Given this list of marker genes USP8, ERBB2, HSP90AA1, EGFR, AKT2, ERBB3, CDC37, NRG2, NRG4, HBEGF, AKT3, EREG, PTPN12 (protein tyrosine phosphatase non-receptor type 12), CUL5, BTC, MATK, NRG1, NRG3, UBA52, ERBIN, AKT1 (NCBI Gene Id 207), RPS27A, UBC, STUB1, ERBB4, PTPN18, RNF41, EGF, UBB, here is a description of the gene set: part of: Signaling by ERBB2 Signaling by ERBB2 can be downregulated by ubiquitination and subsequent proteasome-dependent degradation of ERBB2 or activated ERBB2 heterodimers. In addition, protein tyrosine phosphatases that dephosphorylate tyrosine residues in the C-terminus of ERBB2 prevent the recruitment of adapter proteins involved in signal transduction, thus attenuating ERBB2 signaling.<br>STUB1 (CHIP) and CUL5 are E3 ubiquitin ligases that can target non-activated ERBB2 for proteasome-dependent degradation. RNF41 (NRDP1) is an E3 ubiquitin ligase that targets ERBB3 and activated heterodimers of ERBB2 and ERBB3 for proteasome-dependent degradation by ubiquitinating ERBB3.<br>Two protein tyrosine phosphatases of the PEST family, PTPN12 and PTPN18, dephosphorylate tyrosine residues in the C-terminus of ERBB2, thus preventing signal transduction to RAS and PI3K effectors. species: Homo sapiens Reactome Pathway: Downregulation of ERBB2 signaling